The following is a description of a gene set: studied in species Homo sapiens Peripheral retinal avascularization Human Gene Set: HP_PERIPHERAL_RETINAL_AVASCULARIZATION, and this is the list of marker genes: TSPAN12, RTL1, FZD4, LRP5, NDP, DLK1, CTNNB1, MEG3 (NCBI Gene Id 55384), ZNF408